The following is a description of a gene set: species: Homo sapiens Nasogastric tube feeding Human Gene Set: HP_NASOGASTRIC_TUBE_FEEDING The condition of inability to eat normally treated by placement of a thin tube through the nose into the stomach that is then used to carry food., and this is the list of marker genes: SLC35A2, NONO, GNB2, WAC, GRIN1, COL4A6, ACSF3, ZNF699, PACS1, RECQL4, ASXL3, PSAT1, MYL1, CLCNKB, MOGS, PLP1, FOXP3, ANAPC1, SRCAP, KNSTRN, COL4A5, MAGEL2, CLCNKA, AASS, NACC1, ACTA1, VPS50, HECW2, ASPA, ABCD1, MPDU1, EPM2A, BSND, SIM1, NHLRC1 (NHL repeat containing E3 ubiquitin protein ligase 1), PIK3CD, CARS2, ALG2, DPM2, MFF, KCNK9, PTCD3